The following is a description of a gene set: Mouse Gene Set: REACTOME_RAF_ACTIVATION RAF activation species: Mus musculus, and this is the list of marker genes: Braf, Kras, Ppp1cb, Ppp2r1a, Src, Map2k1, Calm2, Ywhab, Ppp2r5d, Calm3, Camk2d, Ppp2r5c, Ppp2r5a, Ppp2cb, Mark3, Ppp2r5b, Hras, Camk2b, Ppp2r1b, Brap, Ppp2ca, Map3k11, Camk2a, Mras, Ppp2r5e, Phb1, Ksr1, Ppp1cc, Raf1, Shoc2, Map2k2, Calm1, Araf, Camk2g, Jak2